The following is a description of a gene set: The chemical reactions and pathways resulting in the breakdown of a protein or peptide encoded by an aberrant message and associated with a stalled ribosome. Degradation is initiated by the covalent attachment of a ubiquitin group, or multiple ubiquitin groups, to the ribosome-associated protein. Mouse Gene Set: GOBP_RIBOSOME_ASSOCIATED_UBIQUITIN_DEPENDENT_PROTEIN_CATABOLIC_PROCESS species: Mus musculus, and this is the list of marker genes: Zfp598 (zinc finger protein 598), Ascc2, Rnf10, Ascc3, Nemf, Trip4, Ltn1